Given this list of marker genes PIK3CA, NRAS, GRB2, PIK3R1, PDGFRA, SOS1, KRAS, PIK3R2, STAT1, PIK3CB, STAT3, HRAS (HRas proto-oncogene, GTPase), here is a description of the gene set: Signaling by PDGFRA transmembrane, juxtamembrane and kinase domain mutants Human Gene Set: REACTOME_SIGNALING_BY_PDGFRA_TRANSMEMBRANE_JUXTAMEMBRANE_AND_KINASE_DOMAIN_MUTANTS species: Homo sapiens